The following is a description of a gene set: part of: SLC-mediated transmembrane transport Reactome Pathway: Transport of vitamins, nucleosides, and related molecules This event has been computationally inferred from an event that has been demonstrated in another species.<p>The inference is based on the homology mapping from PANTHER. Briefly, reactions for which all involved PhysicalEntities (in input, output and catalyst) have a mapped orthologue/paralogue (for complexes at least 75% of components must have a mapping) are inferred to the other species. electronically inferred by orthology from the curated human pathway studied in species Mus musculus, and this is the list of marker genes: Slc29a3, Slc28a1, Lcn12, Slc27a1, Slc29a2, Slc25a5, Pdzd11, Slc5a6, Apod, Slc35c1 (solute carrier family 35, member C1), Slc35d1, Slc27a6, Slc25a4, Lcn9, Slc35b2, Slc35d2